Given this list of marker genes ODC1, PAFAH1B1, KCNK9, CPLX1, NXN, EXTL3, SMG9, KDM6A, BAP1, YWHAE, COX7B, NSUN2, TCF4, ARID1B, CD96, CAMK2G, DCHS1, CTBP1, PRR12, CCL2, ATIC, NSD2, DICER1, LIMK1, TBXT, TBX4, WNT5A, DEAF1, WLS, DYRK1A, MAN2C1, DVL1, TMCO1, CDK10, KMT2D, RFC2, AFF3, FUZ, FZD2, EIF4H, CLIP2, FGFRL1, ROR2, USP9X, DHPS, SHANK3, PSMD12, H4C5, LIG4, POLA1 (DNA polymerase alpha 1, catalytic subunit), RAB23, DHCR7, SETD5, GTF2IRD2, SCARF2, FANCB, ERI1, KMT2A, SOX9, GTF2I, GRB10, WNK3, NADSYN1, BICD2, ELN (elastin), HNRNPK, LIFR, TBL2, PIGG, KANSL1, ZNF699, SMOC1, SMC5, VPS37D, FAT4, TBX5, FANCF, B9D2, LETM1, HOXA13, VANGL1, RNU4-2, ZIC3, PRMT7, TMEM270, SUGCT, ERGIC1, GTF2IRD1, ANK1, GNB2, FKBP6, NCAPG2, HIC1, SMAD4, BAZ1B, NCF1 (neutrophil cytosolic factor 1), HCCS, B3GLCT, EPHB4, BUD23, DNAJC30, SPOP, RPL10, KIF15, CAPRIN1, OTUD6B, CAPN15, DPAGT1, VANGL2, NELFA (negative elongation factor complex member A), ASXL1, STX1A, SCYL2, COL25A1, RMRP, COLEC10, METTL27 (methyltransferase like 27), CTCF, NDUFB11, ALPL, TAF1 (TATA-box binding protein associated factor 1), AEBP1, EBP, DVL3, MED12, MASP1, here is a description of the gene set: studied in species Homo sapiens Skin dimples are cutaneous indentations that are the result of tethering of the skin to underlying structures (bone) causing an indentation. Skin dimple Human Gene Set: HP_SKIN_DIMPLE